The following is a description of a gene set: Genes containing one or more binding sites for (Tardbp) in their promoter regions (TSS -1000,+100 bp) as identified by GTRD version 20.06 ChIP-seq harmonization. from publication Yevshin I, Sharipov R, Kolmykov S, Kondrakhin Y, Kolpakov F (PMID 30445619) Mouse Gene Set: TARDBP_TARGET_GENES studied in species Mus musculus, and this is the list of marker genes: mt-Th, mt-Nd5, mt-Tn (NCBI Gene Id 17738), mt-Ta, Sfi1, mt-Tl1, mt-Ts2, mt-Tl2, mt-Tc, mt-Ty, mt-Nd1